The following is a description of a gene set: Mouse Gene Set: GOMF_DOUBLE_STRANDED_RNA_BINDING Binding to double-stranded RNA. studied in species Mus musculus, and this is the list of marker genes: Slc3a2, Supv3l1, Adarb2, Ago4, Adad1, Ddx60, Prkra, Vim, Hnrnpu, Tfrc, Ago1, Tubb4b, Zbp1, Dhx9, Nlrp1a, Oas1g, Dicer1, Oas1c, Ddx1, Oas1e, Yrdc, Aptx (NCBI Gene Id 66408), Rc3h1, Zfp346, Rigi, Ddx21, Tarbp2, Zfr2, Prkrip1, Nlrp1b, Dgcr8, Dhx36, Dhx58, Ifih1, Oas1f, Lsm14a, Oas2, Zfr, Hmgb1, Strbp, Tuba1b, Dhx30, Mrpl44, Oasl2, Msn, Ago2, Dus2, Ilf3, Ago3, Oas1d, Stau1, Tlr7, Dhx15, A1cf, Oas1a (2'-5' oligoadenylate synthetase 1A), Eif4a1, Oasl1, Hsp90ab1, Tlr3, Dhx33, Hspd1, Mbnl1, Elavl1, Ilf2, Mtdh, Sidt1, Sidt2, Hspa1a, Rftn1 (raftlin lipid raft linker 1), Adarb1, Oas3, Tlr8, Eif4b, Eif4h, Oas1b, Nlrp6, Eif2ak2, Oas1h, Actn1, Stau2, Cltc, Adar, Myh4, Adad2, Rc3h2